The following is a description of a gene set: species: Homo sapiens Genes whose expression peaked at 40 min after stimulation of MCF10A cells with EGF. Human Gene Set: AMIT_EGF_RESPONSE_40_MCF10A Signaling pathways invoke interplays between forward signaling and feedback to drive robust cellular response. In this study, we address the dynamics of growth factor signaling through profiling of protein phosphorylation and gene expression, demonstrating the presence of a kinetically defined cluster of delayed early genes that function to attenuate the early events of growth factor signaling. Using epidermal growth factor receptor signaling as the major model system and concentrating on regulation of transcription and mRNA stability, we demonstrate that a number of genes within the delayed early gene cluster function as feedback regulators of immediate early genes. Consistent with their role in negative regulation of cell signaling, genes within this cluster are downregulated in diverse tumor types, in correlation with clinical outcome. More generally, our study proposes a mechanistic description of the cellular response to growth factors by defining architectural motifs that underlie the function of signaling networks. from publication Amit I, Citri A, Shay T, Lu Y, Katz M, Zhang F, Tarcic G, Siwak D, Lahad J, Jacob-Hirsch J, Amariglio N, Vaisman N, Segal E, Rechavi G, Alon U, Mills GB, Domany E, Yarden Y (PMID 17322878), and this is the list of marker genes: MIS18BP1, FOS, EGR1, CCN1, TIMM44 (translocase of inner mitochondrial membrane 44), TUFT1, NDUFB6, BUB1, KLF6, ZFP36, ADM (NCBI Gene Id 133), JUN, DUSP5, HSDL2, EGR3 (early growth response 3), UNC93B1, GNS (NCBI Gene Id 2799)